Given this list of marker genes NQO1, AKR1A1, AKR1C3, KEAP1, AKR1C2, HMOX1, NFE2L2, AKR1C1, AKR1C4, here is a description of the gene set: Human Gene Set: KEGG_MEDICUS_ENV_FACTOR_METALS_TO_KEAP1_NRF2_SIGNALIG_PATHWAY Pathway Definition from KEGG: Metals -> ROS -| KEAP1 -| NRF2 => (HMOX1,NQO1,AKR) Metals to KEAP1-NRF2 signalig pathway. Pathway ID: N01413. Pathway type: Env factor. Pathway class: nt06226 KEAP1-NRF2 signaling. studied in species Homo sapiens